The following is a description of a gene set: Any process that results in a change in state or activity of a cell or an organism (in terms of movement, secretion, enzyme production, gene expression, etc.) as a result of an isoquinoline alkaloid stimulus. An isoquinoline alkaloid is any member of a group of compounds with the heterocyclic ring structure of benzo(c)pyridine which is a structure characteristic of the group of opium alkaloids. Human Gene Set: GOBP_RESPONSE_TO_ISOQUINOLINE_ALKALOID species: Homo sapiens, and this is the list of marker genes: GRIA1, DRD3, PPP5C, CARTPT, PPP2R2A, FOSB, OPRM1, PPP1R9B, ABCB1, PRKCE, PRKCG, ADRA2A, ADCY8, PPP1R1B, CREB1, SLC1A1, DRD2